The following is a description of a gene set: from publication Chen Y, Wang X (PMID 31504780) studied in species Homo sapiens Human Gene Set: MIR4509 Genes predicted to be targets of miRBase v22 microRNA hsa-miR-4509 in miRDB v6.0 with MirTarget v4 prediction scores > 80 (high confidence targets)., and this is the list of marker genes: NFIB, DICER1, LHFPL1, MYF6, MISP, RBM18, PTBP2, DNAJB4, TPR, MMD, CELF4, ZKSCAN8, ZEB2, SEPTIN8, UBE2H, MECP2, ANKLE1, WDR1, ZNF697, MYO1E, CASK, NKAIN2, ATP11AUN, DENND1B, EFEMP1, ERH, MXI1, GBP5, ZNF268, EFHC1, MYF5, DLC1, NEU1, MMGT1, HIBADH, ZNF589, CDCA4, TBL1XR1, SPAG6, ANKRD1, GAB2, ITCH, STAU2, LDHB, ACSL4, TRPS1, DCAF8, TNRC6C, SLC7A7, NF2, SUCNR1 (NCBI Gene Id 56670), TRAK1, AUNIP, MTREX, SIGLEC12, MBNL3, NANOG, ZNF559-ZNF177, C5orf24, MED26 (mediator complex subunit 26), CRYBG3, CDH8, ZFP90, PRKX, ZNF708, UBQLN2, TGFBRAP1, PPARGC1A, PTK2, BCHE, ZNF773